The following is a description of a gene set: species: Mus musculus Mouse Gene Set: GOBP_V_D_J_RECOMBINATION The process in which immune receptor V, D, and J, or V and J gene segments, depending on the specific receptor, are recombined within a single locus utilizing the conserved heptamer and nonomer recombination signal sequences (RSS)., and this is the list of marker genes: Atm, Yy1, Tcf3, Hmgb1, Polb, Prkdc, Xrcc4, Rag2, Foxp1, Lef1, Lig4, Dclre1c, Nhej1, Rag1, Xrcc6, Bcl11b, Dcaf1, Cyren, Ezh2, Tcf7